Given this list of marker genes DST, SLC12A2, CLDN10, ELP1, FGFR2, PAX1, ERCC6, PIGQ, AAAS, FGFR3, AP1B1, NGLY1, TP63, LIFR, MAPT, ERCC8, TRAPPC11, PRDM12, MADD, SOX10, SETBP1, ERCC4, ALX4, MRAP (NCBI Gene Id 56246), FGF10, FOXL2, GMPPA, here is a description of the gene set: Human Gene Set: HP_DECREASED_LACRIMATION species: Homo sapiens Decreased lacrimation Abnormally decreased lacrimation, that is, reduced tear production.